Given this list of marker genes ALDH5A1, SDHA, SDHAF3, SUCLG2, GAD1, SDHB, GAD2, SUCLA2, here is a description of the gene set: studied in species Homo sapiens The chemical reactions and pathways involving succinate, also known as butanedioate or ethane dicarboxylate, the dianion of succinic acid. Succinate is an important intermediate in metabolism and a component of the TCA cycle. Human Gene Set: GOBP_SUCCINATE_METABOLIC_PROCESS